The following is a description of a gene set: species: Homo sapiens Exanthem Human Gene Set: HP_EXANTHEM A widespread rash., and this is the list of marker genes: EPB42 (NCBI Gene Id 2038), MVK, HLA-DRB1, SRSF2, SPTA1, RUNX1, SLC4A1, ANK1, CBL, ASXL1, ZNFX1, STX11, NLRP3, TBK1, TNFRSF1A, SPTB, IKBKG, STXBP2, PRF1, KIT, BTNL2, TET2, UNC13D